Given this list of marker genes SOX30, MGAT4A, SPECC1L, RAB3IP, PIGN, MRPS23, CPEB4, MARCHF5, ZNRF3, RPP14, PHF21A, SNAP25, NASP, TREML1, KIF21A, IRAG1, STIM2, THOC2, MAD2L1BP, NAA50, ZNF410, DMRT3, BTG2, CHD2, GATAD1, SMURF1, ZNF474, TLE4, PIGS, GRM8, HSBP1, ZFP1, MYO9B, KRT222, UBASH3B, GREB1, MEIS2, TMEM184C, TBC1D12 (TBC1 domain family member 12), FLRT3, MBD1, LRRC58, ATXN1L, TANC2, DECR2, ZHX3, DPH6, BHLHE22, SLC19A4P, PIK3CA, PPTC7, LSM11, RB1CC1, YPEL2, ECPAS, CEACAM8, ABRAXAS1, ACO2, MIDEAS, TMTC1, EPN2, AGO4, ROCK1, PTPN20, RAD51B, BCKDHB, CDH17, CEBPE, STRAP (NCBI Gene Id 11171), STAU1, MAL2, TMEM182, PTPRE, SELE, HAPSTR1, SYT10, TNFRSF21, MEX3C, MYH8, MOB3B, DUSP23, PTBP2, TPM1, VBP1, C1orf122, DSCC1, MICAL2, PALD1, MAN2A1, ARCN1, MYO1D, GLT1D1, ZBTB34 (NCBI Gene Id 403341), MCC, DUXA, PPP1R1B, FAM53B, COL2A1, ABR, PRICKLE2, SLC66A3, DCLK1, LINC02953, USP16, ZNF516, AP1AR, NCAN, SEC62, TTC39C, here is a description of the gene set: from publication Chen Y, Wang X (PMID 31504780) Genes predicted to be targets of miRBase v22 microRNA hsa-miR-3157-5p in miRDB v6.0 with MirTarget v4 prediction scores > 80 (high confidence targets). species: Homo sapiens Human Gene Set: MIR3157_5P